Given this list of marker genes FGFR2, RPS19 (ribosomal protein S19), EMILIN1, SALL4, HOXA13, FBXW11, RAD51C, EIF4A3, TBX5, FGD4, here is a description of the gene set: Human Gene Set: HP_SMALL_THENAR_EMINENCE Underdevelopment of the thenar eminence with reduced palmar soft tissue mass surrounding the base of the thumb. studied in species Homo sapiens Small thenar eminence